The following is a description of a gene set: Mouse Gene Set: MCCLUNG_COCAINE_REWARD_5D DeltaFosB (a truncated form of FosB) and CREB (cAMP response element binding protein) are transcription factors induced in the brain's reward pathways after chronic exposure to drugs of abuse. However, their mechanisms of action and the genes they regulate remain unclear. Using microarray analysis in the nucleus accumbens of inducible transgenic mice, we found that CREB and a dominant-negative CREB have opposite effects on gene expression, as do prolonged expression of DeltaFosB and the activator protein-1 (AP-1) antagonist DeltacJun. However, unlike CREB, short-term and prolonged DeltaFosB induction had opposing effects on gene expression. Gene expression induced by short-term DeltaFosB and by CREB was strikingly similar, and both reduced the rewarding effects of cocaine, whereas prolonged DeltaFosB expression increased drug reward. Gene expression after a short cocaine treatment was more dependent on CREB, whereas gene expression after a longer cocaine treatment became increasingly DeltaFosB dependent. These findings help define the molecular functions of CREB and DeltaFosB and identify clusters of genes that contribute to cocaine addiction. Genes up-regulated in the nucleus accumbens (a major reward center in the brain) after 5 days of cocaine treatment. species: Mus musculus from publication McClung CA, Nestler EJ (PMID 14566342), and this is the list of marker genes: Hps4, Top2a, Znrf1 (zinc and ring finger 1), Dlg4, Celf2, Stx1b, Pou2f1, Atp1b2, Actl6b, Kcnd2 (NCBI Gene Id 97339), Fscn1, Smarca2, Kif23, Camk2a, Adora2a, Tspan7, Hspa5, Wbp11, Sh3gl3, Mark2, Krt16, Phb2, Pde4b, Tubb4a, Tm9sf3, Sox10, Coro2b, Nptn, H1f10, Dnajb9, Nectin2, Actr2, Cacna2d3 (calcium channel, voltage-dependent, alpha2/delta subunit 3), Adissp (NCBI Gene Id 67326), Palm, Actn1, St6galnac5, Mrm3, Gad1, Gadd45a (NCBI Gene Id 13197), Golga4, Zfp64, Vamp2, Cck, Ear14, Baiap2, Nell2, Gria4, Fmnl1 (NCBI Gene Id 77175), Penk, Mtmr9, Sdhc, Unc93b1, Sec14l1, Mapre3, Per2, Spock2, Itfg1, Gria1, Tmem50b, Ptp4a2, Nrgn, Fbxw7 (NCBI Gene Id 68467), Leng8, Klf13, Eln, Tbr1, Jup (NCBI Gene Id 16480), Stxbp1, Ccn2, Oaz3, Adora1, Ptpn5, Btrc, Syp